Given this list of marker genes Vcpkmt, Tlr9, Sln, Ltf, Tsc1, Mrln, Pln, Agrn, Oxa1l, Tnni3, Atp5if1, Pxk, Zfas1, Ppif, 1810037I17Rik, Tnnt2, Sirt1, Smim6, Ublcp1, here is a description of the gene set: studied in species Mus musculus Any process that stops or reduces the rate of an ATP-dependent activity. Mouse Gene Set: GOBP_NEGATIVE_REGULATION_OF_ATP_DEPENDENT_ACTIVITY